Given this list of marker genes H19, PMAIP1, MACROH2A1, CDK8, MIR675, CDK4, JAG1, RB1, CCND1, CDH1, CTNNB1, MED1, E2F1, TULP3, CSRP2, SOX4, here is a description of the gene set: species: Homo sapiens Human Gene Set: WP_H19_RBE2F1_AND_CDKBETACATENIN_IN_COLORECTAL_CANCER H19, Rb-E2F1, and CDK-beta-catenin in colorectal cancer